Given this list of marker genes KCNA2, KCNQ2, KCNS2, KCNA3, KCNA10, KCNH6, KCND3, KCNC4, KCNB2, KCNS1, KCNQ1, KCNV2, KCNH1, KCNAB2, KCNC2, KCNG2, KCNQ3, KCNAB3, KCNH5, KCNAB1, KCND1, KCND2 (potassium voltage-gated channel subfamily D member 2), KCNC1, KCNH4, KCNH3, KCNF1, KCNQ4, KCNA7, KCNH8, KCNH2, KCNB1, KCNC3, KCNV1, KCNG1, KCNA4, KCNH7, KCNA1, KCNG4, KCNQ5, KCNA6, KCNG3, KCNA5, KCNS3, here is a description of the gene set: studied in species Homo sapiens part of: Potassium Channels Reactome Pathway: Voltage gated Potassium channels Voltage-gated K+ channels (Kv) determine the excitability of heart, brain and skeletal muscle cells. Kv form octameric channel with alpha subunits that forms the pore of the channel and associated beta subunits. The alpha subunits associate with beta subunits with a stoichiometry of alpha4beta4.The alpha subunits have been classified into 12 families, 1-12 with several representatives from each family. Members of Kv 1-4 form both homotetramers and heterotetramers, however, members of Kv 5-12 form functional heterotetramers. Kv's are expressed in the axon, at axon nodes, somatodendritic sites and axon termini.